The following is a description of a gene set: species: Mus musculus Mouse Gene Set: GOCC_PARANODAL_JUNCTION A highly specialized cell-cell junction found in vertebrates, which forms between a neuron and a glial cell, and has structural similarity to Drosophila septate junctions. It flanks the node of Ranvier in myelinated nerve and electrically isolates the myelinated from unmyelinated nerve segments and physically separates the voltage-gated sodium channels at the node from the cluster of potassium channels underneath the myelin sheath., and this is the list of marker genes: Sptbn2, Jam3, Ank2, Sirt2, Cntnap2, Marveld2, Cldn19, Akr1b1, Sptan1, Cntnap1, Nfasc, Kcna2